The following is a description of a gene set: species: Homo sapiens Genes up-regulated in bone marrow-derived macrophages at 45 min stimulation by LPS: wildtype versus IL6 knockout. IL-10 or IL-6 stimulation of control 129xC57BL/6 murine bone marrow derived macrophages in the presence of LPS. We used microarrays to detail the global programme of gene expression changes in response to IL-6 or IL-10 stimulation in the presence of lipopolysaccharide. BMDMs were isolated from control, IL-6-/-, and IL-10-/- mice on a 129XBL/6 mixed background mice and differentiated in the presence of CSF-1 for 6-7 days. Cells were scraped and plated in 6 well plates at 2x10e6/well. Cells were washed with complete DMEM and rested for 1-2 hr before stimulation with combinations of IL-10 (10 ng/ml), IL-6 (2 ng/ml) or LPS (100 ng/ml) for 45 min or 180 mins. Complete biological replicates were performed. Human Gene Set: GSE5589_WT_VS_IL6_KO_LPS_STIM_MACROPHAGE_45MIN_UP from publication El Kasmi KC, Holst J, Coffre M, Mielke L, de Pauw A, Lhocine N, Smith AM, Rutschman R, Kaushal D, Shen Y, Suda T, Donnelly RP, Myers MG Jr, Alexander W, Vignali DA, Watowich SS, Ernst M, Hilton DJ, Murray PJ (PMID 17114459), and this is the list of marker genes: GSTT2, ACP1, SVBP, KCNQ1OT1, PCMTD2, SSH2, MYL9, DGKZ, MEX3A, RMND5A, FAM168B, ZMIZ1, SHMT1 (serine hydroxymethyltransferase 1), MDM2, GDE1, VCPIP1, EDC3, SNX12, LRP1, EFEMP1, SNAP47, UBE2Q2, ING4, BCAP31, ELP3, HMOX1, TLK1, ZC2HC1A, MED30, NGDN, DHRS3, SCOC, SPTLC2, BRAF, GDF15, FASLG, NADK, ZNF770, LDHA, REV3L, SYNGR1, SPIC (NCBI Gene Id 121599), TREML4, GRK5, MCRIP1, VPS26A, UBAP1, PTEN, DYDC1, CKAP5, GPATCH11, VCP, TPR, RPS15A, TRIM25, PCOLCE2, SRSF1, PDE3B, ESCO1, AHCTF1, ADI1, C5orf22, RPUSD4, GNS, SLC37A2, NPAS4, TBC1D9 (TBC1 domain family member 9), BLTP3B, SON, SMC3, MAOA, KDM2B, PALLD, SCN3B, PIK3CA, POGZ, ADH1C, B3GNT9, SPECC1, ATP7A, PEX16, SUZ12, NATD1, SRSF10, SRD5A1, GALNT15, ACP6, ZNF526, ASPA, THBS3, ZNF24 (zinc finger protein 24), CPSF7, PRICKLE2, RTF2, UBA2, ZFAND4, MYO5A, AVPI1, KIF14, IST1, TMEM65, ZNF207, TCEAL9, B3GNTL1, CREB3L2, MCTP1, HSPA2, HECA, MCOLN1 (mucolipin TRP cation channel 1), FBXO22, ALG1, SRMS, SNX29, XPR1, HSPA8, TASL, SUCLG2, IBA57, RAF1, EPB41L3, OARD1, QRICH1, TGFBR2, ZNF182, CCDC102A, UBQLN2, CLASP2, RAB8B, EPAS1, PDE7A, PRKCH, ERI2, KITLG, SH2D1B, GPX4, VAMP7 (vesicle associated membrane protein 7), TGFBR3, NELFCD, ST8SIA4, LUC7L2, SCARB2, CHMP7, SORD, ATRX, TMEM134, ANGEL2, ETNK2, POLG2, DOCK7, WDFY4, FAM107B, C16orf74, ZC3H8, SNAPC5, NDFIP1, SMPD5, ANGPTL8, GDPD1, HEBP1, STIMATE, KMT5A, GGA2, OAZ1, WWP1, GPX1, DDR2, PANK2, SLC25A51, HEY1, TMEM164, ANKRD33, C1S, ANGPTL3, TCF19, STOM, TXNIP, FABP5, ULK3, ACADS, CDT1, ANXA2, KIAA2013, YBX1, CREG2, STAG2, GTF2H2, ATP6V1D, SIK3, CHCHD2, CSTF2T, PAXBP1, IPO8, NLN, DOP1B, ATP8B3, FTL, PLA2G6, TP53I13, OPHN1